The following is a description of a gene set: Genes predicted to be targets of miRBase v22 microRNA mmu_miR_24_3p in miRDB v6.0 with MirTarget v4 prediction scores > 80 (high confidence targets). Mouse Gene Set: MIR_24_3P from publication Chen Y, Wang X (PMID 31504780) species: Mus musculus, and this is the list of marker genes: Klhdc9, Gad1, Sptlc2, Ranbp10, Cdk16, Cdh7 (cadherin 7, type 2), Zfp980, Kptn, Il1r1, Mrpl45, Snn, Rc3h2, Dusp8, Abhd13, Zxdb, C1qtnf1, Vav2, 2810459M11Rik, Gpr151, Dgkk, Zxdc, Zbtb37, Chmp1b2, Nemp1, Ago4, Mboat7, Pla2g4e, Sema4a, Matr3, Med8, Gm11545, Ttc17, Wnt8b, Tor2a, Calhm4, Add2, Slc25a25, Ptprf, Mapk14, Avl9, B3gnt5, Rap1b, Hnf1b, Abcb9 (ATP-binding cassette, sub-family B member 9), Mecp2, Atad2b, Blzf1, Slc16a2, Rnf2, Rala, Hspb7, 3110082J24Rik, Xpo7, Entpd6, Apba1, Top1, Sesn1, Ube2k (ubiquitin-conjugating enzyme E2K), Rubcn, Pigm, Nfxl1, Cited4, Zfp942, Tmem245, Snhg11, Crat, Klhl1 (kelch-like 1), Btaf1, Rps15a, Foxred2, Nefm, Lrsam1, Ntsr1, Stc2, Agpat1, Per1, Klrb1a, Fyb2, Map6d1 (NCBI Gene Id 208158), Smagp, Zfp446, Grik3, Zfp697, Kcnk2 (potassium channel, subfamily K, member 2), Pgap4, Ugcg, Sart1, 9930012K11Rik, Ndst1, Insig1, Kmt5c, Taok1 (NCBI Gene Id 67240), Bcl2l11, Bco1, Spast (NCBI Gene Id 54171), Adcyap1r1, Prss44, Dhx33, Tceanc2, Zcchc14, Klk10, Ebf2, Kctd21, Mboat1, Luc7l, Slc25a44, Ark2c, Mix23, Acaca, Clcn3, Ptger4, Zfp947, Mbd6, Rasa1, Cmtm4, Plcl2, Snap91, Bhlhe22, Trpm1, Tpmt, Kbtbd13, Nlrp6, Zfp820, Crebl2, Fsd1l, Stx5a, Als2, Pkdcc, Sncaip, Kbtbd6, Klf8, Kcnb1, Tmem161b (transmembrane protein 161B, NCBI Gene Id 72745), Tbc1d24, Fgf11, Nphp1, Calcr, H2ax, Sphkap, Dagla, Gal3st3, B4gat1, Pde1a, Zswim7, Tmed8, Samd4b, Rnf138, Lmtk2, 2510009E07Rik, Zfp975, Sema4b, Nlk (nemo like kinase), Vstm4, Otud5, Atp13a2, Mia3, Ccdc25, Tmem70, Cyb561d1, Dock3, Kif3b, Ncl, Rap1a, Iffo2, Rex2, Sstr1, Dyrk2, Dmrtb1, Tmem267, Skida1 (SKI/DACH domain containing 1), Nup210, Sdf2, Plod2, Neurod1, Ipcef1, Trim66, Apob, Cdkn1b, Kif21b, N4bp1, Nova2, Rasal1, Ppp1r16b, Fam78b, Midn, Magi1, Mrc2, Zfp654, Nrp2, Gnao1, Camk2b, Dlc1, Rnf41, Zfp600 (zinc finger protein 600), Pdgfra, Rmi1, Derl1, Med13, Gorab (golgin, RAB6-interacting), Tfcp2l1, Tada2b, Scml2, Tspan14 (tetraspanin 14), Tmem121b, Rap2c, Agps, Vgll3, Appl2, Kcnip1, Rbm3, Tcf7, Reep1, G6pdx, Dlgap4, Gfer, Diaph1, Lmbr1l, Mau2, Amz1, Lsamp, Lhpp, Gal3st2c, Gfpt1, Tmem164, Dusp16 (NCBI Gene Id 70686), Pml, Rab8a, Nadk2, Amotl2, Cers3 (NCBI Gene Id 74802), Rapgef2 (Rap guanine nucleotide exchange factor (GEF) 2), Oxtr, Zfp811, Arid5a, Polr3d, Trp53bp1, Spon1, Prdm1, Fam210b, Stradb, Polr1e, Fst, Gbx2, Pskh1, Mydgf, Igfbp4, Per2, Ago3, Dmtn, Depdc5, Zfp68, Cnot6, Laptm4b, Sting1, Anks1, Grip1, Specc1, Aldh5a1, Mxi1, Brd8, Zfp981, Nav2 (neuron navigator 2), Chd5